The following is a description of a gene set: A process in which a protein is transported to, or maintained in, the cell periphery. Mouse Gene Set: GOBP_PROTEIN_LOCALIZATION_TO_CELL_PERIPHERY species: Mus musculus, and this is the list of marker genes: Emp2, Git1, Pik3r2, Bbip1, Tnf, Pias1, Arl6, Rhbdf2, Sec16a, Rab29, Kalrn, Pip5k1a, Kif5b, Pals1, Wdr72, Ppp1r9b, Vps26b (VPS26 retromer complex component B), Gorasp2, Atp2b4, Ppil2, Hras, Lypla1, Sqstm1, Trarg1, Ezr, S100a10, Skap1, Ap4m1, Clip3, Ghsr (NCBI Gene Id 208188), Rack1, Mex3b, Gak, Sacm1l, Sorbs1, Eif4g1, Lztfl1, Nhlrc1, Gorasp1, Prepl, Cask, Wdr24, Magi2, Iqsec2, Camk2a, Dok7, Ptpn9, Rock1, Tnik, Tsc2, Plekhf1, Hycc1, Rac1, Ttc8, Sfn (stratifin), Amn, Zdhhc3, Wnk4, Kif1b, Afdn, Lrrc7, Gga2, Dab2, Mesd, Cdh1, Ogt, Musk, Abi3, Rdx, Vamp3, Pik3r1, Ramp1, Tmbim1, Kcnip3, Pgrmc1, Sys1, Zfyve27 (zinc finger, FYVE domain containing 27), Csnk2a1 (NCBI Gene Id 12999), Pdzk1, Sec13, Rapgef2, Actn2, Hycc2, Grip2, Kif2c, Ehd1, Stx8, Gripap1, Epha3, L1cam, Errfi1, Gga3, Rab10, Hectd1, Zdhhc25, Tmed2, Bbs2, Wnk3, Arf6, Neto1, Dlg2, Nptx2 (neuronal pentraxin 2), Picalm, Commd1, Rab26, Efr3b (EFR3 homolog B), Kcnj11, Nsg1, Adcy6 (adenylate cyclase 6), Slc1a1, Mylk, Camk2d, Pkp2, Washc1, Atp2c1, Ar, Mrap, Tub, Jup, Camk2g, Pigw, Map2k1, Itgb1, Cnst, Wnk1, Lyplal1, Rab11fip3, Nptx1, Tspan5, Agr2, Numa1, Snap47, Csk, Nfasc, Stac2, Prkg2, Ins2, Ramp3, Epha2, Akt2, Zdhhc23, Lrp1, Krt18, Arhgap44, Macf1, Lrp6, Acsl3, Adipoq (adiponectin, C1Q and collagen domain containing), Tspan33, Nherf4, Neto2 (NCBI Gene Id 74513), Tgfb1, Palm, Efcab7, Appl1, Pdpk1, Dag1, Ehd3, Blzf1, Fyb1, Prkci, Actr3, Sorl1, Cacna2d2, Plk1 (NCBI Gene Id 18817), Sptbn4, Wnt3a, Mapk10, Tspan18 (NCBI Gene Id 69936), Vwc2, Bcl2l1, Sirt6, Tnfrsf1a, Scrib, Mmp14 (NCBI Gene Id 17387), Optn, Fcer1g, Tmem150a, Grin2c, Grin1 (NCBI Gene Id 14810), Cdk5, Ramp2, Pacs1, Atp1b1, Atp2c2 (ATPase, Ca++ transporting, type 2C, member 2), Slc4a1, Ank2, Mal, Phaf1, Arl3, Ikbkb, Stac3, Smurf1, Flot1, Nbea, Gpsm2, Lypd1, Nrxn3, Clstn1, Ttc7, Tspan14 (NCBI Gene Id 52588), Myadm, Nkd2, Grip1, Arhgef16, Ilk, Ift80, Sec23a, Cnpy4, Epb41, Erbb4, Agrn, Tmem108, Nubp1, Gnai1, Myo5b, Umod, Nrxn1, Akt1, Bag4, Tescl, Akap5, Abca12, Stx4a, Inpp5k, Golph3, P2ry1, Ccdc88a, Lrrc15, Sytl2, Ift20, Nherf1, Golga7, Zdhhc7, Fgf13, Adam22, Rap1a, Kif13a, Gas6, Vti1b, Epm2a, Tm9sf5 (NCBI Gene Id 245423), Flot2, Ehd4, Scp2, Abca2, Tspan15, Clasp2, Bsg, Wdr19, Trem2, Efr3a, Kcnb1 (potassium voltage gated channel, Shab-related subfamily, member 1), Rab38, Zdhhc2, Cltc, Prkcz, C1ql2, Rapgef4, Myo5a, Bbs1, Sco1, Arl13b, Sptbn1, Dlg4, Cacnb3, Scn3b, Tmem88, Cplx1, Zdhhc22, Camk2b, Nptxr, Vamp2, Gpc4, Stac, Epb41l3, Snx27, Rap2a, Numb, Cdh2, Fyb2, Scarb2, Atp1b3, Rab7, Rer1, Rangrf, Zdhhc4, Vps4a, Vil1, Ins1, Adam10, Pgap2, Pacs2, Pkdcc, Clip1, Traf6, Prph2, Vamp5, Dpp6, Gpr158, Zdhhc5 (zinc finger, DHHC domain containing 5), Lhfpl4 (lipoma HMGIC fusion partner-like protein 4), Ap2m1, Atp6ap1, Ehd2, Gga1, Anxa2, Mrap2, Ypel4, Slmap, Nectin3, Pid1 (phosphotyrosine interaction domain containing 1), Myl12a, Cacng3, Flna, Snca, Arfrp1, Pls1, Gpr179, Arl6ip5, Ank1, Frmd8, Tmem59, Ppfia1, Actb (NCBI Gene Id 11476), Dpp10, Rab31, C2cd5, Erbb2, Sapcd2, Ank3, Exoc5, Cd81, Ppp2r5a, Rab11a, Stxbp1, Cib1, Stx7, Lgi1, Tpbg, Wdr59, Rapgef6, Snap23, Pacsin1, Kcnip4, Rab8a, Lgals3, Ttc7b, Ephb2, Stx1b, Crb3, Rab11fip2, Rab34, Rabep1, Stx3, Gabarap, Olfm2, Cnih3, Gper1, Vamp4, Gsk3b, Pkp3, Nsf, Pkp1, Cacng2 (calcium channel, voltage-dependent, gamma subunit 2), Vps35, F11r, C1ql3, Ldlrap1, Rhog, Epb41l2, Cacng7, Egfr, Tesc, Sesn2, Itga3 (integrin alpha 3), Rhoq, Golga4, Gpc6, Lama5, Cacnb2, Rab13, Rock2, Fcho2, Ptch1, Epb41l1, Arl13a, Rilpl1, Gphn, Cav3, Cln3, Csrp3, Itgb1bp1, Rilpl2, Dlg1, Nherf2, Kcnb2, Rapsn, Grin2a, Vamp8, Ngdn, Large1, Golph3l, Pram1, Misp, Prnp, Map7, Negr1, Dchs1, Dennd4c